Given this list of marker genes CDK9, UCHL1, TGFB1, CCNB1, CDK5, PSEN2, XRCC4, RELA, XRCC5, TCF3, CDC37, CD47, CDK4, PTEN, CASP3, MYC, IL6ST, TP53, PSEN1, TXN, here is a description of the gene set: species: Homo sapiens Immunoglobulin light chain amyloidosis (AL) is characterized by a clonal expansion of plasma cells within the bone marrow. Gene expression analysis was used to identify a unique molecular profile for AL using enriched plasma cells (CD138+) from the bone marrow of 24 patients with AL and 28 patients with multiple myeloma (MM) and 6 healthy controls. Class prediction analysis (PAM) revealed a subset of genes, which included TNFRSF7 (CD27), SDF-1, and PSMA2, that distinguished between these 2 groups with an estimated and observed accuracy of classification of 92%. This model was validated with an independent dataset of 11 patients with AL and 12 patients with MM with 87% accuracy. Differential expression for the most discriminant genes in the 12-gene subset was validated using quantitative real-time polymerase chain reaction and protein expression analysis, which upheld the observations from the micro-array expression data. Functional analyses using a novel network mapping software revealed a number of potentially significant pathways that were dysregulated in patients with AL, with those regulating proliferation, apoptosis, cell signaling, chemotaxis, and migration being substantially represented. This study provides new insight into the molecular profile of clonal plasma cells and its functional relevance in the pathogenesis of light chain amyloidosis. Genes down-regulated in immunoglobulin light chain amyloidosis plasma cells (ALPC) compared to multiple myeloma (MM) cells. Human Gene Set: ABRAHAM_ALPC_VS_MULTIPLE_MYELOMA_DN from publication Abraham RS, Ballman KV, Dispenzieri A, Grill DE, Manske MK, Price-Troska TL, Paz NG, Gertz MA, Fonseca R (PMID 15388584)